The following is a description of a gene set: electronically inferred by orthology from the curated human pathway part of: Transport of Mature mRNAs Derived from Intronless Transcripts species: Mus musculus Reactome Pathway: Transport of the SLBP Dependant Mature mRNA This event has been computationally inferred from an event that has been demonstrated in another species.<p>The inference is based on the homology mapping from PANTHER. Briefly, reactions for which all involved PhysicalEntities (in input, output and catalyst) have a mapped orthologue/paralogue (for complexes at least 75% of components must have a mapping) are inferred to the other species., and this is the list of marker genes: Nup93, Seh1l, Nup58, Rae1, Ndc1, Nup42, Slbp, Nup133, Nup155, Nup54, Aaas, Alyref, Nup205, Nup210, Nup85